Given this list of marker genes Prkn, Mmp8, Trim32, Ube2k, Traf2, Laptm5, Cpne1, Adam17, Ripk1, Casp1, Hspa1b, here is a description of the gene set: Any process that activates or increases the frequency, rate or extent of tumor necrosis factor-mediated signaling pathway. Mouse Gene Set: GOBP_POSITIVE_REGULATION_OF_TUMOR_NECROSIS_FACTOR_MEDIATED_SIGNALING_PATHWAY species: Mus musculus